The following is a description of a gene set: Human Gene Set: KEGG_MEDICUS_REFERENCE_AUTOPHAGOSOME_AND_LYSOSOME_FUSION_TETHERING_FACTOR species: Homo sapiens Autophagosome and lysosome fusion, tethering factor. Pathway ID: N01721. Pathway type: Reference. Pathway class: nt06532 Autophagy. Pathway Definition from KEGG: RAB7 == (EPG5,PLEKHM1,BIRC6,HOPS,TECPR2) == LC3-II, and this is the list of marker genes: MAP1LC3C, RAB7A, MAP1LC3B, BIRC6, MAP1LC3A, TECPR2, MAP1LC3B2, RAB7B, VPS11, EPG5, VPS16, VPS18, VPS41, VPS39, VPS33A, PLEKHM1